The following is a description of a gene set: Mouse Gene Set: GOBP_NEGATIVE_REGULATION_OF_B_CELL_PROLIFERATION Any process that stops, prevents or reduces the rate or extent of B cell proliferation. studied in species Mus musculus, and this is the list of marker genes: Cdkn2a, Pawr, Tnfrsf13b, Tsc2, Il10, Atm, Tnfrsf21, Pkn1, Btla, Tyrobp, Btk, Inpp5d, Ctla4, Cd24a, Fcgr2b, Lyn, Cd300a, Casp3, Pten, Rc3h1